Given this list of marker genes PPP1R15B, PPP1R3G, LGALS3, SPNS1, HCAR2, DSC1 (NCBI Gene Id 1823), PDCD6IP, ZNHIT1, IRF2BP2, DCTN2, HMGA1, RFFL, GALK1, UBE2J2, HSPA12A, TNFRSF9, CAVIN1, PRELID1, PSMD3 (NCBI Gene Id 94019), VPS53 (NCBI Gene Id 55275), CCDC86, SOBP (NCBI Gene Id 654119), ATCAY, PDZD11, MCEMP1, TNFAIP3, BZW2, TRPC4AP, PRPF31, TTLL9, TREM2, SH3BGRL3, DUSP4, PAX4, IER3IP1, SPAG8, ARHGAP31, FNBP1L, PHLDA2, MIER2, CYTH1, LAMTOR4, PTPRS, C16orf95, EIF1AX, GPI (NCBI Gene Id 2821), CSF2RB, FADS2, UFM1, PLIN2, APRT, GTF2F1, PER1, GPR152, OLFM4, MAP1LC3A, RASSF2, DNAJB11, TRIO, KCNN3, PYCARD, PAM, BASP1, TRADD, IL6, RBM42, MAFF, KCNG1, AARS1, CHD7, KLF7, MEA1, TAX1BP3, HOPX, PRELID3B, YPEL5, PLAU, KLHL40 (NCBI Gene Id 131377), CCDC89, NUDC, TRIB3, LDHA, LGALS8, MOV10L1, MXD1, TSC22D4, TP53BP2, CDK6, MCTS1, IQGAP3, MICALL2 (MICAL like 2), SLC15A3, C1GALT1C1, RNF126, CCT6B, KLHL25, DNAJC1, SPINT1, SPRY2, SLC7A5 (solute carrier family 7 member 5), SEMA4A (semaphorin 4A), ADAM28, KLF13, ARPP19, CTPS1, WBP1L, SOCS2, SMDT1, RBM15B, PRDX5, C1orf56, TNFAIP6, DGAT1, NFKBIA, SLC2A1, SEC14L4, PICALM, SH3PXD2B, CDH16, PGLS, WWP2, ZNF341, MINDY1, IL15RA, ATXN7L1, LGALS1, ATP6V1G1, BAMBI, TNNI3K, TATDN2, ALDOC, BHLHE40, SNRPF, CCNO, MCC, ADGRG3, S100A6, TRIM29, UPP1, CIAO2A, PPP1R14B (NCBI Gene Id 26472), MBD2, HACD1, CCNC, FGD6, WDR83, PPIL1, GALE, ELMOD3, PTGR1, MAPK13, CTSV, BEND4 (BEN domain containing 4, NCBI Gene Id 389206), ECEL1, POF1B, NUDT3 (NCBI Gene Id 11165), MAFG, FGF13, MROH9, GPR137, VAPA, TBC1D14, ARHGDIA, SAA1, LRFN2, NUCB2, WTAP, UQCC5, GPBP1L1, NPEPPS, GYS1, PLCH1, TMCO6, F2, WFDC2, RNFT2, S100A10, CA13 (carbonic anhydrase 13), FPR2, EFHD2, MAP2K2, CKAP4, HTRA3, LSR, SART1, F2RL2, MIF (NCBI Gene Id 4282), EDN1, PROB1, TUT7, UACA, E2F4, PFDN4, F3, GALNT16, CAGE1, FOXF1, UQCR11, GPR146, CARNMT1, here is a description of the gene set: Human Gene Set: GSE8921_3H_VS_24H_TLR1_2_STIM_MONOCYTE_DN In innate immune responses, activation of Toll-like receptors (TLRs) triggers direct antimicrobial activity against intracellular bacteria, which in murine, but not human, monocytes and macrophages is mediated principally by nitric oxide. We report here that TLR activation of human macrophages up-regulated expression of the vitamin D receptor and the vitamin D-1-hydroxylase genes, leading to induction of the antimicrobial peptide cathelicidin and killing of intracellular Mycobacterium tuberculosis. We also observed that sera from African-American individuals, known to have increased susceptibility to tuberculosis, had low 25-hydroxyvitamin D and were inefficient in supporting cathelicidin messenger RNA induction. These data support a link between TLRs and vitamin D-mediated innate immunity and suggest that differences in ability of human populations to produce vitamin D may contribute to susceptibility to microbial infection. species: Homo sapiens from publication Liu PT, Stenger S, Li H, Wenzel L, Tan BH, Krutzik SR, Ochoa MT, Schauber J, Wu K, Meinken C, Kamen DL, Wagner M, Bals R, Steinmeyer A, Zügel U, Gallo RL, Eisenberg D, Hewison M, Hollis BW, Adams JS, Bloom BR, Modlin RL (PMID 16497887) Genes down-regulated in monocytes in response to M. tuberculosis 19 kDa lipopeptide: 3h versus 24h.